Given this list of marker genes Fabp4, Abcd3, Abcd2, Abcc1, Fabp5, Fabp1 (fatty acid binding protein 1, liver), Abcd1, Slc27a1, Slc27a2, Fabp2, Slc27a4, Mfsd2a, Fabp3, Cd36, Slc27a6, Slc27a5, Slc2a1, Abcd4 (NCBI Gene Id 19300), here is a description of the gene set: species: Mus musculus Enables the transfer of a long-chain fatty acid from one side of a membrane to the other. A long-chain fatty acid has an aliphatic tail containing 13 to 22 carbons. Mouse Gene Set: GOMF_LONG_CHAIN_FATTY_ACID_TRANSMEMBRANE_TRANSPORTER_ACTIVITY